The following is a description of a gene set: Human Gene Set: GOBP_T_CELL_HOMEOSTASIS species: Homo sapiens The process of regulating the proliferation and elimination of T cells such that the total number of T cells within a whole or part of an organism is stable over time in the absence of an outside stimulus., and this is the list of marker genes: JAK3, PPP3CB, AKT1, BAX, TGFB1, SIT1, NCKAP1L, BCL2L11, STAT5A (NCBI Gene Id 6776), DNAJA3, SLC39A3, LMO1, SPNS2, SLC46A2, CORO1A, IL7R (interleukin 7 receptor), RAG1, IL2, PRDX2, TNFSF14, TSC22D3, LGALS2, FADD, AIM2, ZC3H8, P2RX7, PPP2CA, RC3H2 (NCBI Gene Id 54542), RC3H1, GPR15LG, GPAM, STAT5B, CHST3, PPP2R1A, BCL2, IL20RB, CASP3, CCNB2, FAS, PPP2R3C, SIVA1, RIPK3, TGFB2, TCIRG1, IL2RA, PMAIP1, GPR174, FOXN1, FOXP3, LGALS9